Given this list of marker genes TFB2M, ZCCHC10 (zinc finger CCHC-type containing 10), ERCC6, GRAMD2B, TSC22D2, GLI3, KDM2A, ADH1C, CALR, CCNYL1, ADAMTS20, DCDC2, SLC38A2, KLF4, ORAI1, UBL5, ARID5A, ADAM17, RHOBTB1, BEX1, TTI2, RAB11FIP5, MS4A1, QRICH1, HEXIM1, SBSN, PNRC1, TFIP11, ST8SIA6, KLF9, FOXP1, SATB1, ESM1, LYPD6B, PAQR3, IRF2BP2, UBE3D, IGDCC4, ZRSR2, SLCO4C1 (NCBI Gene Id 55385), RBM4B, ANGPTL4 (angiopoietin like 4, NCBI Gene Id 93954), PPP1R16B, CASP4, DAZ2, RPS21, CCNB1IP1, BCL2, UBN1, RNF19A, GJA5, RBP2, CCR7, THEMIS, FUS, ZBTB39, DBR1, ABHD17B, RPS27, ATP6V0E2, RGS2, FOSB, TLNRD1, CREBL2, PIM1, NOL11, C17orf75, STX5, FAM149A, ACOT2, UBC, DNAJB9, PGM2L1, ST3GAL1, MED29, ZNF449, PHF13, MEF2D (NCBI Gene Id 4209), ELL, FAM81A, ZNF622, TTLL3, SIGMAR1, RAB33B, AP1S3, ZFP64, TOPORS, H2AZ1, LY6D, NETO2, PIP4K2A, IL6R, ETF1, DENND2D (NCBI Gene Id 79961), AFF1, TUBA1A, FAM107B, MYLIP, RNF220, SMCHD1, PLA2G4F, IL17B, EFNA2, SCARNA13, PARP8, IFITM2, TAGAP, PROKR1, OTUD1, INPP5F, ADORA1, PKP4, FAM204A, SOCS1, REV3L, FHL5, SPMIP4, USP48, CLEC4D, GRK4, NTN4, RAMP3, TIMM9, LRATD2, CDT1, TRAF1, LRCH1, RIOK1, LRIG1, RPS29, DDA1, MARCHF7, IRS2, MSI2, WDR33, SFR1, ING3, CTH, RARA, SUCO, GRAMD4, OCIAD2, GPRIN3, TDRP, AHCTF1, DDX27, TNXB, BTK, RBM39, NMRK1, ZYG11B, WDR43, POLG2, DUSP10, CEACAM21, NRN1, SNX24, CCSAP, KLB, ZSCAN29, SGK1, RFLNB, ATF3, ASPG, TMEM242, RCL1, MYH10, B4GALT1, SLU7, ZNF462, WDR45B, PDE4B, MIDEAS (NCBI Gene Id 91748), LRP1, PLEKHF2, SNHG3, PRSS41, CTR9, NR4A2, INPP4B, CHD1, HAPSTR1, PDXK, RIPK2, C1orf198, C9orf72, PPP1R12B, LSM1 (LSM1 homolog, mRNA degradation associated), FLVCR1, OR2C1, TMEM81, KPNA1, ADRB2, EID2, PIK3AP1, IL24, BANK1, IFT140, ANGEL2, MMP10, here is a description of the gene set: Human Gene Set: GSE20366_EX_VIVO_VS_DEC205_CONVERSION_DN Genes down-regulated in comparison of TregLP versus DEC-Pept Convert (see Table 1S in the paper for details). studied in species Homo sapiens Regulatory T (Treg) cells that express the FoxP3 transcription factor are essential for lymphoid homeostasis and immune tolerance to self. Other non-immunological functions of Treg cells, such as controlling metabolic function in adipose tissue, are also emerging. Treg cells originate primarily in the thymus, but can also be elicited from conventional T cells by in vivo exposure to low-dose antigen or homeostatic expansion, or by activation in the presence of TGFβ in vitro. Treg cells are characterized by a distinct transcriptional signature controlled in part, but not solely, by FoxP3. For a better perspective on transcriptional control in Treg cells, we compared gene expression profiles of a broad panel of Treg cells from various origins or anatomical locations. Treg cells generated by different means form different sub-phenotypes identifiable by particular combinations of transcripts, none of which fully encompass the entire Treg signature. Molecules involved in Treg effector function, chemokine receptors, and the transcription factors that control them are differentially represented in these subphenotypes. Treg cells from the gut proved dissimilar to cells elicited by exposure to TGFβ, but instead they resembled a CD103+Klrg1+ subphenotype preferentially generated in response to lymphopenia. from publication Feuerer M, Hill JA, Kretschmer K, von Boehmer H, Mathis D, Benoist C (PMID 20231436)